The following is a description of a gene set: studied in species Mus musculus Genes predicted to be targets of miRBase v22 microRNA mmu_miR_758_5p in miRDB v6.0 with MirTarget v4 prediction scores > 80 (high confidence targets). from publication Chen Y, Wang X (PMID 31504780) Mouse Gene Set: MIR_758_5P, and this is the list of marker genes: Gpatch2 (G patch domain containing 2), Pltp, Dcn, L3hypdh, Fbxl5, Mical2, Ccdc87, Cadps2, Onecut2, Zfp367, Ankrd44, Fam169b, Mknk1, Tmem33, Fbn1, Zfp157, Znhit6, Rnf111, Traf7, Mff (mitochondrial fission factor), Pa2g4, Negr1, Fam174a, Cnot6, Nudt4, Cpne4, Kmt2a, Grm5, Kcnq5 (potassium voltage-gated channel, subfamily Q, member 5), Mrpl53, Scd3, Rad21, Chrm3